Given this list of marker genes Cd200r1, Cd80, Gramd1c, Lsamp, Gm17928 (NCBI Gene Id 100416122), Gm15712, Poglut1, Igsf11, Ccdc191, Mir6540, Gm26074, Gm36903, Tex55, D930030I03Rik, Usf3, Arhgap31, Cd200r4, Sidt1 (NCBI Gene Id 385649), Gm49738, Ndufs5-ps, Gm19142, Pla1a, Gm15530, Naa50, Spice1, Gm36742, Gm15575, Gm19522, Tigit, Qtrt2, Cfap44, Upk1b, Gm22543, Gm15803, Atp6v1a, Adprh, Nepro, Gm9968, Gm15713, Zbtb20, Mir3081, Popdc2, Drd3, Mir568, B4galt4, Gm22500, Gm15711, Boc, Zdhhc23, 4932412D23Rik, Gm15802, Gtpbp8 (GTP-binding protein 8 (putative), NCBI Gene Id 66067), Tmem39a, Timmdc1, Gm15953, Gm5063, Gap43, Gm8609, Gm5964, Cd200r2, here is a description of the gene set: species: Mus musculus Mouse Gene Set: chr16B4